Given this list of marker genes SERPINC1, TIMP1, CST1, CST2, SPINK7, TFPI2, SERPINB5, SERPINB8, XIAP, SERPINA9, SERPINH1 (NCBI Gene Id 89588, serpin family H member 1), SERPINI1, FETUB, SNCA, SERPINB9, SPINT3, PTTG1, SERPINB7, BIN1, SERPINA3, TIMM50, SPOCK2, CRIM1, ITIH5, ITIH2, CSTA, CARD17P, NAIP, SPINT2, PEBP1, VSIR, GBP5, MANSC4, KNG1, RECK, AIM2, CST11, WFDC3, NLRC4, PAPLN, SERPINI2, PROS1, SPINK14, WFDC10B, THBS1, SPINK9, ITIH4, CST4, NLRP12, UCHL5 (ubiquitin C-terminal hydrolase L5), SLCO1B7 (solute carrier organic anion transporter family member 1B7 (putative)), SERPINB6, HSPD1, SERPINE3, OPRPN, A2M, CARD16, PSMF1, CRB2, SERPINB2, RARRES1, SLCO1B3-SLCO1B7, SERPINF1, SORL1, CST5, LXN, WFDC13, GAPDH, NLRP1, PSME1, SERPINA6, FURIN, SMR3B, ITIH6, SPINT4, PSENEN, AHSG, WFDC5, WFIKKN1, PSMD14, SERPINA7, CARD8, LTF, PSME2, AMBP, SERPINA4, APAF1, NLRP7, NRDC (NCBI Gene Id 4898), SERPINB13, CSN2, CARD18, WFDC2, PZP, SERPINF2, BIRC7, C3, WFIKKN2, SPOCK1, WFDC9, A2ML1, BST2, NLRP3, SERPINA5, NCSTN, WFDC6, CSTL1, TIMP2, NGF, SPP2, SERPINB10, ABCA2, LPA, PI3, PRNP, ANOS1, APLP2, SERPING1, CPAMD8, APH1A, AGT, GBP2, SPINK8, CST9LP1, TFPI, SPINK13, SERPIND1, SERPINE1, APH1B, SPINT1, SPOCK3, CD109, COL4A3, SERPINB12, SFRP2, APP, SERPINA1, MALT1, CST3, C4B, BIRC5, SPINK4, COL28A1, SERPINB11, PCSK1N, USP14, WFDC1, CST9, EPPIN, COL6A3, SPINK5, CSTB, WFDC10A (NCBI Gene Id 140832), SERPINB4, CST8, BAD, ITIH3, LCN1, C5, ITIH1, TIMP3, ANXA2, SLPI, CST9L, PSME3, WFDC8, C4A, COL7A1, HRG, SERPINE2, SPINK6, ROCK2, LGMN, SMR3A, SERPINA10, RENBP, ADRM1, HMSD (histocompatibility minor serpin domain containing), SERPINA2, SERPINA11, TIMP4, SLCO1B3, CST7, ST20, SPINK1, SERPINA12, SERPINB1, SPINK2, WFDC11, NDUFA13, CAST, WFDC12 (NCBI Gene Id 128488), CST6 (cystatin E/M), C3P1, PYCARD, BIRC6, SERPINB3, here is a description of the gene set: Human Gene Set: GOMF_ENDOPEPTIDASE_REGULATOR_ACTIVITY studied in species Homo sapiens Binds to and modulates the activity of a peptidase, any enzyme that hydrolyzes nonterminal peptide bonds in polypeptides.